Given this list of marker genes HOXB13, NUP88, CDK16, DUOX2 (NCBI Gene Id 82430), DDX56, FAT1, GGCT, DLL3, WT1-AS, LONRF3, TRAIP, CELF3, ELOB, NLE1, MED27, CD22, IGLVIVOR22-1, SAP130, AUNIP (NCBI Gene Id 79000), PRPF3, SLC35C1, here is a description of the gene set: Pediatric adrenocortical tumors (ACT) are rare and often fatal malignancies; little is known regarding their etiology and biology. To provide additional insight into the nature of ACT, we determined the gene expression profiles of 24 pediatric tumors (five adenomas, 18 carcinomas, and one undetermined) and seven normal adrenal glands. Distinct patterns of gene expression, validated by quantitative real-time PCR and Western blot analysis, were identified that distinguish normal adrenal cortex from tumor. Differences in gene expression were also identified between adrenocortical adenomas and carcinomas. In addition, pediatric adrenocortical carcinomas were found to share similar patterns of gene expression when compared with those published for adult ACT. This study represents the first microarray analysis of childhood ACT. Our findings lay the groundwork for establishing gene expression profiles that may aid in the diagnosis and prognosis of pediatric ACT, and in the identification of signaling pathways that contribute to this disease. Human Gene Set: WEST_ADRENOCORTICAL_CARCINOMA_VS_ADENOMA_UP species: Homo sapiens from publication West AN, Neale GA, Pounds S, Figueredo BC, Rodriguez Galindo C, Pianovski MA, Oliveira Filho AG, Malkin D, Lalli E, Ribeiro R, Zambetti GP (PMID 17234769) Up-regulated genes in pediatric adrenocortical carcinoma (ACC) compared to the adenoma (ACA) tumors.